The following is a description of a gene set: studied in species Homo sapiens Human Gene Set: HP_DIABETIC_KETOACIDOSIS Diabetic ketoacidosis A type of diabetic metabolic abnormality with an accumulation of ketone bodies., and this is the list of marker genes: NEUROD1, ABCC8, SLC12A3, CEL, KCNJ11, ZFP57, KLF11, BLK, PDX1, PAX4, GCK, PLAGL1, HYMAI, HNF1A, CIDEC, INSR, APPL1, HNF4A, CLCNKB, INS